The following is a description of a gene set: Binding to a WW domain of a protein, a small module composed of 40 amino acids and plays a role in mediating protein-protein interactions via proline-rich regions. studied in species Homo sapiens Human Gene Set: GOMF_WW_DOMAIN_BINDING, and this is the list of marker genes: ENTREP3, TRAF4, LITAF, KIF20B (NCBI Gene Id 9585), NDFIP1, SHISA5, WBP11, CDC25C, WBP1, ENAH, PPARG, WBP2NL, TP63, DAZAP2, NFE2, RAPGEF2, PMEPA1, TNK2, SCNN1B, NDFIP2, SCNN1A, PRRG4, TREX1, SCNN1G